Given this list of marker genes ACTB, ARPC5L, ARPC2, ARPC3, ARPC5, CTTN, ARPC4, ARPC1A, ACTG1, ACTR3, ARPC1B, SRC, ACTR2, here is a description of the gene set: Human Gene Set: KEGG_MEDICUS_PATHOGEN_SHIGELLA_IPAC_TO_ACTIN_SIGNALING_PATHWAY Shigella IpaC to Actin signaling pathway. Pathway ID: N01079. Pathway type: Pathogen. Pathway class: nt06135 Cytoskeletal regulation (viruses and bacteria). Pathway Definition from KEGG: IpaC -> SRC -> CTTN -> ARP2/3 -> (ACTB,ACTG1) species: Homo sapiens